The following is a description of a gene set: Mouse Gene Set: GOBP_CD4_POSITIVE_ALPHA_BETA_T_CELL_PROLIFERATION The expansion of a CD4-positive, alpha-beta T cell population by cell division. species: Mus musculus, and this is the list of marker genes: Il2, Vsir, Arg2, Lgals9, Cblb (NCBI Gene Id 208650), Cd55b, Il2ra, Cd44, Foxp3, Ripk2, Cd81, Card11, Irgm1, Cd24a, Prkcq, Lilrb4a, Twsg1, Tgfbr2, Tnfsf18 (tumor necrosis factor (ligand) superfamily, member 18), Cd28, Cd55, Tarm1, Cd3e, Itch, Tnfrsf14, Ndfip1, Xcl1, Cd274